Given this list of marker genes DNAJA3, KLK13, COL5A3, MYO15A, UROS, SCN1B (sodium voltage-gated channel beta subunit 1), BRF1, TSC1, ZNF75D, RAB40A (NCBI Gene Id 142684), CYP2E1, B9D1, PALS2, LAMP1, SHMT1, LIN37, AGTPBP1, VNN1, ZBTB6, CDK2AP2, TSC22D3, SIPA1, ZFHX2, GCAT, DHX30, RPL18, MTSS1 (MTSS I-BAR domain containing 1), OSGIN2, ZMYM1, SPOUT1 (NCBI Gene Id 51490), ARMC8, TPTE2, GALC, B4GALT1, SNCG, ASB5, FNBP1, DHRS3 (dehydrogenase/reductase 3), EVPL, METTL22, CACNB3, PLXNA3, TBXAS1, CTNS (NCBI Gene Id 1497), CPPED1, BORCS8-MEF2B, TST, AP1G2, INTS2, here is a description of the gene set: Human Gene Set: MODULE_285 species: Homo sapiens Genes in the cancer module 285.